The following is a description of a gene set: Human Gene Set: MENON_FETAL_KIDNEY_2_NEPHRON_PROGENITOR_CELLS species: Homo sapiens from publication Menon R, Otto EA, Kokoruda A, Zhou J, Zhang Z, Yoon E, Chen YC, Troyanskaya O, Spence JR, Kretzler M, Cebrián C (PMID 30166318), and this is the list of marker genes: HES1, MAL, RPSA, JAG1, TUBB2B, HMGA1, RPSA2, LHX1, EPCAM, HOXA10, RPL7P1, TRIB2, MST1L, ERBB4, LIMCH1, POU3F3, RAB3IP, HOXD8, HOXB7, DCDC2 (NCBI Gene Id 606719), BTG1, UTRN, ODC1, RPL3, CCND1, PLEKHA1, RPS2, HIPK2, HSP90AA1, HOXB3, RPLP0, AFDN, MECOM (MDS1 and EVI1 complex locus), ANP32E, ABLIM1, DBI, LAMB1, EIF3F, MARCKSL1, CCDC198, CD24, EMX2, SOX4, RPLP0P6 (NCBI Gene Id 649049)